Given this list of marker genes DAB2, TMED2, LZTFL1, MRAP, MRAP2, CLTC, LYPD1, LRRC15, GBP1, PPP2R5A, ANXA13, RHOQ, TGFB1, TMEM59, TMBIM1, BCL2L1, LYPLA1, CSK (C-terminal Src kinase), WNK3, LYPLAL1, RSC1A1, WNK1, ABI3, PID1, SAPCD2, NUMB, SFN, PICALM, PPFIA1, AP2M1, PKDCC, WNK4, here is a description of the gene set: Any process that stops, prevents or reduces the frequency, rate or extent of protein localization to cell periphery. Human Gene Set: GOBP_NEGATIVE_REGULATION_OF_PROTEIN_LOCALIZATION_TO_CELL_PERIPHERY species: Homo sapiens